Given this list of marker genes Mapk3, Tgfbr2, Hoxa5, Bmp4, Shh, Map2k2, Mapk1, Rspo2 (R-spondin 2), Lrp6, Map2k1, Wnt7b, Ctnnb1, here is a description of the gene set: The process in which a trachea is generated and organized. The trachea is the portion of the airway that attaches to the bronchi as it branches. studied in species Mus musculus Mouse Gene Set: GOBP_TRACHEA_MORPHOGENESIS